The following is a description of a gene set: Any process that activates or increases the frequency, rate or extent of receptor recycling. species: Mus musculus Mouse Gene Set: GOBP_POSITIVE_REGULATION_OF_RECEPTOR_RECYCLING, and this is the list of marker genes: Arap1, Anxa2, Nsf, Bves, Vamp3, Scrib, Ramp3, Dab2, Rab29, Inpp5f, Psen2, Eps15, Snca, Ece1, Psen1, Agtr1a, Nsg1